The following is a description of a gene set: Mouse Gene Set: GOBP_NEGATIVE_REGULATION_OF_LIPID_BIOSYNTHETIC_PROCESS species: Mus musculus Any process that stops, prevents, or reduces the frequency, rate or extent of the chemical reactions and pathways resulting in the formation of lipids., and this is the list of marker genes: Snai2, Apoc3, Sik1, Rest, Atg7, Lpcat1, Gfi1, Slc27a1, Obp2a, Mup3, 3110082I17Rik (NCBI Gene Id 73212), Pdgfa, Snai1, Fgf15, Serpina12, Malrd1, Insig2, Acadvl, Akr1c18, Asxl3, Mup11, Nr0b1, Ubr4, Mup1, Trib3, Hrh1, Ormdl3, Idi2, Cyp7a1, Wdtc1 (WD and tetratricopeptide repeats 1), Dkkl1, Insig1, Bmp5, Ceacam2, Klhl25, Cyp27b1, Atp1a1, Mup5, Brca1 (NCBI Gene Id 12189), Sik2, Nr1h4, Tmx1, Ormdl1, Sirt1, Abca2, Dkk3, Ggcx, Wnt4, Apoe, Acadl, Nfkb1, Erlin1, Pde8b, Mup2, Erlin2, Pdgfb, Ceacam1, Sod1, Dcaf5, Apoc1, Ccdc3, Prox1 (NCBI Gene Id 320240), Pibf1, Sphk1, Mup4, Bmp2, Gper1, Prmt3, Ormdl2